Given this list of marker genes Exo1, Msh3, Xpc, Msh4 (mutS homolog 4), Setd2, Pms1, Rpa1, Mcm9, Msh2, Msh6, Pcna, Hmgb1, Rpa3, Hdac10, Mutyh, Msh5, Mlh1, Prkcg, Rnaseh2a, Rnaseh2c, Rpa2, Rnaseh2b, Pms2, Mlh3, Axin2, here is a description of the gene set: Mouse Gene Set: GOBP_MISMATCH_REPAIR A system for the correction of errors in which an incorrect base, which cannot form hydrogen bonds with the corresponding base in the parent strand, is incorporated into the daughter strand. The mismatch repair system promotes genomic fidelity by repairing base-base mismatches, insertion-deletion loops and heterologies generated during DNA replication and recombination. studied in species Mus musculus